Given this list of marker genes SULF2, MIR573, HHIP, DSTYK, NRXN1, OTX2, MIR1-1, LRIT3, SPRY2, FAM20C, GPC1, MIR503, THBS1, MIR149, WNT4, NGFR, FGFBP3, MIR16-1, SPRY3, WNT5A (NCBI Gene Id 7474), CREB3L1, NOG, SHISA2, SMOC2, NPTN, SULF1, PRKD2, MIR424, PRDM14, FUZ, FGF2, SPRY4, SPRY1, CTNNB1, GATA3, RUNX2, APLN, OFD1, ITGB1, FGFBP1, MIR146A (microRNA 146a), here is a description of the gene set: species: Homo sapiens Human Gene Set: GOBP_REGULATION_OF_FIBROBLAST_GROWTH_FACTOR_RECEPTOR_SIGNALING_PATHWAY Any process that modulates the frequency, rate or extent of fibroblast growth factor receptor signaling pathway activity.